Given this list of marker genes Hspa9, Dnajc3, Dnajb6, Nup62, Dnaaf6rt (dynein axonemal assembly factor 6, retrotransposed), Ubl4a, Prnp, H2-M2, Fgb, Dnajb3, Rps3, Cyp2b10, H2-Q7, H2-K1, Prkn, St13, Ctsc, Spn, Ttc4, Ern1, Dlst, Grpel1, Cd24a, Tsc1, H2-M5, Scarb2, Dnajb9, Iqcg, Sod1, Dnajb7, Trp53, Dmp1, Stip1, Tg, H2-M10.1, Mettl21a, H2-Q6 (NCBI Gene Id 636948), Tfrc, Dnlz, Rnf207, Dnajc8, Get4, Pacrg (NCBI Gene Id 69310), Usp13, H2-M10.2, Cyp1a1, Dnajb14, Lrp2, Gpr37 (NCBI Gene Id 269834), Erp29, Nod2, Dnajc9, Hspe1-rs1, Dnaja4, Snca, Ppef2, Amfr, Tert, Timm9, Cftr, Dnajc2, Fgf1, Birc5, Nr3c1, Dnajb12, Cdc37, Cdc37l1, Hspe1, Hspb6, Hikeshi, H2-T3, Ogdh, Dnajb5, Cyp2e1, Hspa2, Dnajb1, Bak1, H2-M11, Dnajb13, Pdpn, H2-Q10, Plg, Grn, Stub1, H2-Q2, Stau2, Dnajc10, Mvd, H2-M10.6, Timm10, H2-M9, Hspa8, H2-M10.3, Bag4, Ahsa2, Dnajb2, H2-M10.5, Fnip1, Hes1, Ficd, Dnajb8, Fkbp1a, H2-T22, Syvn1, Gnb5, Wrap53, Atp1a3, Timm44, App, Slc12a2, Sugt1, Hscb, Bag5, Vwf, Pfdn6, Pglyrp1, Lbr, Sacs, Cdkn1b, Ahsa1, H2-D1 (NCBI Gene Id 547343), Bag2, Ago2, Bin1, Sdf2l1, Sgtb, H2-T10, Cdk1, Dnaja2 (DnaJ heat shock protein family (Hsp40) member A2), Hdac8, Dnaja3, Birc2, Hspd1, Grpel2, Ahr, Bag3, Ppid (NCBI Gene Id 67738), Dnaja1, Dnajb4, Bax, H2-Q1, Tsacc, Atp7a, H2-Q4, Dnajc1, Slc25a17, Bag6, Atp1a2, Fnip2, H2-M1, Ptges3l, Stmn3, Cyp27a1, Bag1, Alb, Creb1, Cp, Mapt, Ksr1, H2-M10.4, Dnajc18, Atp1a1, Cdc25a, Ptges3, here is a description of the gene set: species: Mus musculus Mouse Gene Set: GOMF_PROTEIN_FOLDING_CHAPERONE_BINDING Binding to a chaperone protein, a class of proteins that bind to nascent or unfolded polypeptides and ensure correct folding or transport.